Given this list of marker genes Rab7, Farp1, Mtmr1, Lmnb1, Fam169a, Arhgap12, Depdc1b, Baiap2l1, Akap12, Tor1aip1, Mcam, Diaph2, Steap3, Esyt1, Basp1, Cav1, Pik3r2, Baiap2l2, Vangl1, here is a description of the gene set: studied in species Mus musculus This event has been computationally inferred from an event that has been demonstrated in another species.<p>The inference is based on the homology mapping from PANTHER. Briefly, reactions for which all involved PhysicalEntities (in input, output and catalyst) have a mapped orthologue/paralogue (for complexes at least 75% of components must have a mapping) are inferred to the other species. electronically inferred by orthology from the curated human pathway part of: RHO GTPase cycle Reactome Pathway: RHOF GTPase cycle